Given this list of marker genes Mtmr10, 4930426L09Rik, Ep300, Erbb3, Topbp1, Or2ag16, Ska1, Mrpl27, Acsl3, Calr, Hmg20b, Gm14024, Smdt1, Ddx5, Anapc16, Dhx32, 1700122E12Rik, Qrsl1, Col9a1, Gm28857, Prkcd, Ifitm3 (NCBI Gene Id 66141), Cep95, Naa16, Mapre3, 4833418N02Rik, Ttc7, Tm9sf2, Fn1, Ascc1, Ptpn23, Gpd2, Mir7665, Smad9, Tcp11, Polr3a, Ptpn22, Tmem106a, Brd4, Scrn2, Gjc1, AA914427, Ftsj1, Mobp, Gm19409, Itpripl2, Cfl2, Nanp, Nabp2, Utp14b, Pcf11 (PCF11 cleavage and polyadenylation factor subunit, NCBI Gene Id 97363), Cox18, 4933427D14Rik, Ccdc28b, Acbd5, Tbx20, Rnf41, Smoc1, Zfp984, Pou5f1, Chd1, Ushbp1, Gm15377, Diaph3, Cdk8, Nubpl, Ccdc107, Prpf40b, Babam1, Fam43a, Pnpt1, Ndfip2, C1qtnf5, Rnf19b, Mamstr, Cmtr1, Fbxl13, Gm11779, Srebf1, Ints3, Fst, Kcnj10, H2-T24, Zfp384, Bcan, Wfs1, Hoxd3os1, Hdac11, Prdm9, Arid2 (NCBI Gene Id 77044, AT-rich interaction domain 2), 1700086P04Rik, Asic1, Fus, Ninl, Tex264, Repin1 (NCBI Gene Id 58887), Atp6v1c1, Msrb2, Ado, Gpr15lg, Timm44, Lrrc3b, Slain2, Pgam1, Dmgdh, C230034O21Rik, Inhca, 1110025M09Rik, Atp6v0b, Mgat5, A330035P11Rik (NCBI Gene Id 319727), Cdc42bpb, Eme1, Krtap20-22, H2-T13, Itgav (integrin alpha V), Armc10, Chrm3, Lsr, Jund, here is a description of the gene set: species: Mus musculus Mouse Gene Set: GM2004_GM14419_UNIPROT_A2ARL5_UNREVIEWED_TARGET_GENES from publication Yevshin I, Sharipov R, Kolmykov S, Kondrakhin Y, Kolpakov F (PMID 30445619)